The following is a description of a gene set: electronically inferred by orthology from the curated human pathway studied in species Mus musculus Reactome Pathway: Amino acids regulate mTORC1 This event has been computationally inferred from an event that has been demonstrated in another species.<p>The inference is based on the homology mapping from PANTHER. Briefly, reactions for which all involved PhysicalEntities (in input, output and catalyst) have a mapped orthologue/paralogue (for complexes at least 75% of components must have a mapping) are inferred to the other species. part of: Cellular response to starvation, and this is the list of marker genes: Kics2, Rraga, Castor1, Rragc, Atp6v1c2, Atp6v1f, Atp6v0d1, Lamtor5, Wdr59, Wdr24, Flcn, Fnip2, Atp6v1g2, Fnip1, Castor2, Lamtor2, Bmt2, Rheb (NCBI Gene Id 19744), Seh1l, Atp6v0e, Lamtor4, Atp6v0e2, Sesn2, Tcirg1, Atp6v0c, Atp6v1e2, Lamtor1, Szt2, Atp6v1g3, Atp6v1a, Atp6v1d